The following is a description of a gene set: Human Gene Set: GSE32423_MEMORY_VS_NAIVE_CD8_TCELL_IL7_UP species: Homo sapiens from publication Ventre E, Brinza L, Schicklin S, Mafille J, Coupet CA, Marçais A, Djebali S, Jubin V, Walzer T, Marvel J (PMID 22942430) Effects of IL-4 on CD8 T cells functions are largely unknown. IL-4 induces survival and proliferation of CD8 T cells, but several studies suggest that IL-4 could also affect several functions of CD8 T cells such as cytotoxicity. Our team has shown that IL-4 repress the expression of Ccl5 in vitro. To define more precisely the impact of IL-4 on CD8 T cells, we performed a whole genome expression microarray analysis of naive and memory CD8 T cells cultured in presence or absence of IL-4. This approach allowed us to define the IL4-gene-expression signature on CD8 T cells. Genes up-regulated in comparison of memory CD8 T cells treated with IL7 versus naive CD8 T cells treated with IL7., and this is the list of marker genes: CWC22, MICAL1, CEP170B, DTX4, TMEM181, TAF9B, UST, RINL, BEND6, TMEM100, DOP1B, YES1, IFT70B, APOM, VPS39, C1orf216, ADCY2, GCG, TMEM37, ELAPOR1, ACYP2, SIX4, NMI, GGT6, UBC, KDM4D, ARHGEF12, SLC25A28, DHRS11 (NCBI Gene Id 79154), CAMK2B, RLF, ANKH, ST8SIA1, PRXL2C, MAP3K9, LGALSL, SRPK2, CNRIP1, ATOSB, RGR, LMBR1, EIF3F (eukaryotic translation initiation factor 3 subunit F), GAS7, RGS20, HRH2, DPP4 (NCBI Gene Id 1803), ATOSA, SLC12A1, CTSW, VIPR1, EXT1, FABP12, ZBTB42, SPSB1, FBXO4, CXCR5, GRINA, SPECC1, MAN2C1, SNRNP70, SELENOT, SNTA1, DENND4C, EML3, SGMS1, EI24, PKN3, PTTG1, SBNO2, SEMA4F, MAN1C1, FSTL1, IPCEF1, SUSD4, MFAP5, FAM20C, UNC5CL, DNAJA4, IFNAR2, SPICE1, ARHGAP18, PDE7A, DAAM1, PARP14, ISCA2, RNF39, NRP1, RNF141, CNDP1, FBXW7, NEAT1, CAMK2A, HLA-DOB, ZDHHC13, MYO1F, SRXN1, C1QTNF4, VWA7, SLC18B1, KLF6, GIMAP4, PNPLA7, FBXO30, CAMK2N1, P2RY14, MAP3K4, TBC1D32, ATP8B4, USP48, POLR3F, SMC4, LZTS2 (leucine zipper tumor suppressor 2), ZNF592, PCDH19, FCHO2, PRSS12, BMPR1A, FGF1, CASTOR1, RUNX2, EID2, SMAD5, IL18RAP, HASPIN, CUTC, KIF13B, KCTD4, SLC52A3 (solute carrier family 52 member 3), FRMD5, HEG1, CLN3, CA11, MEGF11, SMPD5, KCNN3, CYP4V2, CHST11, DIP2A, HBS1L, KLRG1, MYORG, TRIM3, ATP11A, MPZL3, FAM241B (family with sequence similarity 241 member B), LRRC18, PBX3, MX2, FASLG, CBX7 (NCBI Gene Id 23492), HOPX, HMGB1, THRAP3, RNFT2, FNDC10, PPIL4, TTBK2, BTBD6, C11orf54, STK11IP, CRYBG3, FZD4, OSBPL9, HOXB1, TIGAR, ATP8B1, IAPP, TP53INP1, PTPN13, GPR15, CACNA1A, STOML1, CCDC171, NT5C3A, IRF6, NANOS1, HHATL, ST8SIA6, BANK1, XDH, UNC50, CD200R1L, STK39, BEND4, IFFO1, LCE2B, TMEM150C, DPP7, KLHL7, EVI2B, NSUN6, MPPE1, SESN3, USP53, RANBP10, GPC1, CMPK2, JKAMP, HIGD1C, MAGEH1